The following is a description of a gene set: Mouse Gene Set: GOBP_REGULATION_OF_OXIDATIVE_STRESS_INDUCED_INTRINSIC_APOPTOTIC_SIGNALING_PATHWAY studied in species Mus musculus Any process that modulates the frequency, rate or extent of an oxidative stress-induced intrinsic apoptotic signaling pathway., and this is the list of marker genes: Gpx1, Parp1, Ppia, Mmp2 (matrix metallopeptidase 2), Hspb1, Fgf2, Nfe2l2, Sod1, Mcl1, Park7, Mapk7, Adcy10, Fyn, Prodh, Ubqln1, Sfpq, Vnn1, Rack1, Fzd1, Sod2 (superoxide dismutase 2, mitochondrial), Bag5, Atf4, Il10, Gata4, Prkn (parkin RBR E3 ubiquitin protein ligase), Sirt1, P4hb, Hif1a, Nox1 (NCBI Gene Id 278150), Pink1, Nme5, Nono, Ctnnb1, Fbxw7, Pycr1, Fbxo7, Nol3, Trem2, Trap1, Wnt1